The following is a description of a gene set: tRNA processing in the mitochondrion Human Gene Set: REACTOME_TRNA_PROCESSING_IN_THE_MITOCHONDRION species: Homo sapiens, and this is the list of marker genes: PRORP, TRNT1, MT-RNR1, TRMT10C, HSD17B10 (hydroxysteroid 17-beta dehydrogenase 10), ELAC2, MT-RNR2